The following is a description of a gene set: Neighborhood of ITGA2 Neighborhood of ITGA2 integrin, alpha 2 (CD49B, alpha 2 subunit of VLA-2 receptor) in the MORF expression compendium Human Gene Set: MORF_ITGA2 studied in species Homo sapiens, and this is the list of marker genes: DBT, APOBEC1, COL8A1, RREB1 (NCBI Gene Id 6239), FBXL4, CDC73, TTTY1, IFNA10, LORICRIN, SUPT3H, SLC4A8, EXOC4, TLL1, CD8A, DNAJC22, GUCY2F, GPR171, PTPRB, SPA17, KRT2, PART1, MAP2, DMD, SLC6A2, ITGA2, GLRA3, COL14A1, SLC15A1, PHOX2B, PSG1, IFNA8, ST8SIA1, ADAMTSL3, ZSCAN26, CXCL5, NR3C2, NHEJ1, LGI1, IL7, CLCN3, COL19A1, STAC, KRT34, OPCML, IFNA2, HEPH, CADM4, ZNF132, SERPINA4, TANC2, LDB3, VSTM4, PTPN20, NPFF, EYA1, RAD51D